Given this list of marker genes Fermt1, Ctnnb1, Wnt10b, Gsdma3, Wnt5a, here is a description of the gene set: studied in species Mus musculus Any process that modulates the frequency, rate or extent of timing of anagen, the growth phase of the hair cycle. Mouse Gene Set: GOBP_REGULATION_OF_TIMING_OF_ANAGEN